The following is a description of a gene set: Human Gene Set: KEGG_MEDICUS_REFERENCE_MITOCHONDRIAL_COMPLEX_UCP1_IN_THERMOGENESIS studied in species Homo sapiens Pathway Definition from KEGG: CxI == CxII == CxIII == CxIV == ATPase -> UCP1 mitochondrial complex - UCP1 in Thermogenesis. Pathway ID: N01691. Pathway type: Reference. Pathway class: nt06529 Thermogenesis., and this is the list of marker genes: COA5, NDUFC2, COA3, ATP5F1A, SDHD, CYC1, UQCRFS1, COX15, NDUFA6, NDUFAF2, NDUFAF5, NDUFS2, COX11, NDUFA4, UQCRC2, COX5A, NDUFB10, NDUFS3, ATP5PO, NDUFV2, COX16, COX8A (cytochrome c oxidase subunit 8A), NDUFB8, COX6B1, NDUFS6, NDUFA2, NDUFS1, NDUFB9, NDUFA10, UQCRB, ATP5F1E, NDUFS4, NDUFS7, NDUFA11, COX20, NDUFA9, NDUFAF1, SDHA, NDUFA8, NDUFB7, MT-ATP6, COX14, NDUFB11, NDUFA13, SDHC, ATP5F1D, NDUFA12, UQCRQ, COX10, NDUFV1, COX4I1, UCP1 (NCBI Gene Id 7350), NDUFAF8, NDUFAF4, NDUFB3, NDUFS8, NDUFAF6, COX6A2, NDUFA1, COA6, SDHB, NDUFAF3